The following is a description of a gene set: Human Gene Set: HP_TIBIAL_TORSION Twisted position of the tibia (shin bone) associated with pathological rotation of the leg. Tibial torsion species: Homo sapiens, and this is the list of marker genes: SCN1A, SLC29A3, PRR12, PCDH19, TTI1, HCN1 (hyperpolarization activated cyclic nucleotide gated potassium channel 1), GABRA1 (gamma-aminobutyric acid type A receptor subunit alpha1), FIBP, SCN2A, ADGRV1, COL9A2, STX1B, COL9A3, SCN9A, GABRD, RBM8A, GABRG2, PRRT2, SLC26A2, DDX6, COL2A1, TAF4, FGF13, SCN1B